Given this list of marker genes Itga2, Prkca, Tgfb1, Sdc3, Vtn, Fgf2, Itgb5, Sdc1, here is a description of the gene set: part of: Non-integrin membrane-ECM interactions This event has been computationally inferred from an event that has been demonstrated in another species.<p>The inference is based on the homology mapping from PANTHER. Briefly, reactions for which all involved PhysicalEntities (in input, output and catalyst) have a mapped orthologue/paralogue (for complexes at least 75% of components must have a mapping) are inferred to the other species. electronically inferred by orthology from the curated human pathway species: Mus musculus Reactome Pathway: Syndecan interactions